The following is a description of a gene set: Human Gene Set: GOBP_MAGNESIUM_ION_TRANSPORT species: Homo sapiens The directed movement of magnesium (Mg) ions into, out of or within a cell, or between cells, by means of some agent such as a transporter or pore., and this is the list of marker genes: KCNJ2, ZDHHC13, NIPA1, CNNM2, SLC41A3, SLC41A1, SLC41A2, NIPA2, MRS2, NIPAL3 (NCBI Gene Id 57185), NIPAL2, MAGT1, MMGT1, NIPAL4, TRPM7, CLDN16, TRPM6, TUSC3, CNNM4 (cyclin and CBS domain divalent metal cation transport mediator 4), NIPAL1 (NCBI Gene Id 152519), TMEM94